Given this list of marker genes BRCA2, RIPK1, OCRL, CCDC40, ALPL, AP3D1, ALDH18A1, RAG1, SPI1, SELENON, IRF3, DYNC2I2, SCN9A (NCBI Gene Id 93955), UBAP2L, IL17RA, SH3KBP1, TSC2, CD3E, TTC7A, RELA, UBE2A, FMO3, MPEG1, NPHS1, DLX4, H4C3, POLE, PRKCD, DPF2, ADNP, MAGT1, NFIX, STAT6, DLL3, EP300, MYO5A, CCBE1, CCDC65, PIGP, MYH3, ALOXE3, FANCF, PRMT7 (NCBI Gene Id 54496), ATP6AP2 (NCBI Gene Id 95880), P4HTM, GLRA2, EPG5, ACBD6, DYRK1A, GRIN1, GAS2L2, GNS, TFE3, RNF168, RFC2, VANGL1, CFAP74 (NCBI Gene Id 93196), MAGEL2, GINS1, CEACAM3, IGHM, AMN, RPL10, NFKB2, PCNT, SLC39A7, NRAS, MC2R, DNAI2, BICC1, CFAP52, RSPH3 (radial spoke head 3), IKZF3, CRELD1 (cysteine rich with EGF like domains 1), NDN, HACD1, MBTPS2, CD40LG, TYMS (NCBI Gene Id 7298), CHAT, BMP4, APRT, DEAF1, TNPO3, ZNF341, CLXN, TERT, FERMT3 (FERM domain containing kindlin 3), C5, SPAG1, ADORA2A, CITED2 (NCBI Gene Id 154106), HELLS, FCGR3A, UNC13D, STXBP2, DAW1, NUP214, SNRPN, RNU7-1 (NCBI Gene Id 100147744), FUCA1, TGM1, TNFSF11 (NCBI Gene Id 8600), CTBP1, SMARCB1, DLG1, ALG13, C3 (complement component 3), TXNRD2, LEP, MMEL1, MAD2L2, FHL1, SPINK5, G6PC3, CPLX1, IKBKB, TARS1, FZD2, CD247, HPGD, FOXJ1, ERCC2 (NCBI Gene Id 7269), TBX1, RAD21, PDGFRA, SIM1, CCDC103, TP53, RYR1, SPTBN4, IGLL1, HGSNAT, KRAS, FOXC2, MAN2B1, ASXL3, CTNNB1, UNG, VARS1, GBA1, TRAF3IP2, CFAP410, COL11A2, HLA-DPA1, PSENEN, IL7R, RAB27A, JAGN1, DNAAF5, SOX11, SLC25A22, ORC6, STAT2, PRKAR1B, MEGF10, MIF, IDS, HBB, CTC1, IGKC, FBXW7, AARS1, DNMT3B, AQP5, IL2RB, SUCLG1, CFD, SMARCA4, SF3B1, ERAP1, WASF1, CD70, POLA1, WFS1, PIK3CG, GALC, DDOST, COL6A2, SKIC2, SLC37A4, CISD2, PLOD1, DNAI1, RECQL, NEUROD2, SP110, C4B, POLD3, SCN2A (NCBI Gene Id 94312), PURA, SCN1B, COL11A1, BCOR, BCHE, IL12RB1, GTF2IRD1, MYPN, PRIM1, BACH2, RSPH4A, WAC, TLR7, CSF3R, GTF2H5, TONSL, NLRC4, CD19, USP48, TNNI3, DEPDC5, TMC8, GNB2, RASGRP1, CCDC22, TMEM70, LAMTOR2, TRAIP, SPIB, RAI1, VAMP1, PLP1, PHKB, HLA-DRB1, SAMD9L, IL12A-AS1, TECPR2, ARPC1B, KANSL1, CR2, FIP1L1, PLCG2, NCF4, AK2, CD28 (CD28 molecule), KCTD1, HBG1, ICOSLG, EYA4, TOP3A, ARPC5, MBL2, JAK1, CLPB, PKD2, COL5A1, MAPK1, THOC6, MCM4, FUT8 (NCBI Gene Id 2530), ANKRD17, GATA2, SCN11A, TSEN34, C8A (complement C8 alpha chain), KRT5 (NCBI Gene Id 3852), TP63, PWAR1, VPS4A (vacuolar protein sorting 4 homolog A), LETM1, SLC35A1, KAT5, PKP1, OCA2, FOXP1, CASP8, SMARCE1, SPTBN1, PHKG2, DCTN4, FARSB, GATA4, TAOK1, UROD, TRPS1, ZAP70, GALNS, NPAP1, SLC19A1, MSX1, TRAF3, MED13L, GORAB, PIGG, TAPBP, CYBA, GAA, NDUFC2, SDR9C7, SBDS, SIK1, IGBP1, RTEL1, IL23R, PSMB10, SERAC1, COG7, ALDH1A2, ERCC4, ARID1A, RFX7, TTC12, CACNA1C, LONP1, XRCC2 (NCBI Gene Id 7516), FADD, PNP, POGZ, P4HA2, CTCF (NCBI Gene Id 10664), GRM7, PAK2, SH2D1A, RFT1, HBG2, FOCAD, SLX4, NELFA, PKD1, NBN, CARD11, POLR2A, IL7, CHRNA3, GLI3, TERC, TRIP11, TPP2, BNC2, GPR35, CLCA4, DNAAF3, KLRC4, POLR3GL, HOXA13, NEK10, GTF2IRD2, RNF113A, FCSK, KMT2B, TSC1, ITK, LAMA2, KATNIP, CXCR2, AGR2, ITGA7, AIRE, MPLKIP, NIPAL4, VPS37D, KLF1, TET2, UROS, DNAAF6, SOX17, TCF4, REL, DOCK2, RPGR, RSPH1, ZBTB16, SMARCC2 (NCBI Gene Id 6601), LTBP4, CD3G, PEX5, SLC39A4, SCNN1A, REEP1, FLNC, IFT56, SNAP25, GFM2, STX1A, EFEMP2, BCR, COL13A1, NHLRC2, PLG, CLDN16, FANCB, IL21, CD4, DIAPH1, MGAT2, AGA, MRTFA, TK2, FBXL4 (NCBI Gene Id 26235), KCNJ6, NLRP3, CCNO, SLC29A3, MED12, WDR26, MGP, SGSH, DGCR6, SLC1A4, DNAJB11, H4C5 (H4 clustered histone 5), RMRP, RALGAPA1, GOT2, WDR19 (WD repeat domain 19), SCNN1B (sodium channel epithelial 1 subunit beta), SATB1, PML, LAMC2, MTM1, C4A, DNAAF1, RBCK1, TRRAP, WASHC5, CRKL, SRY, VPS51, LMNB1, TIMMDC1, IL12A, SRP54, CFB, SLC9A3, A2ML1, SLF2, RAC2, TNFSF12, SMARCA2, ALG5, SMN1, CDH23, GATA6, BCL10, PNKP, POLR1A, GTF2I, SLC7A9, SETD2, NNT, GRIA1, SRCAP, SEMA4D, TRIP4, SAMD9, DPYSL5, IL2RA, C1GALT1C1, CCR2, IRF2BP2, DNAL1, DNAH9, SDCCAG8, RNH1, PYROXD1, SFTPC, CFTR, FKBP6, MGME1, PTEN, DPM2, IFNAR2, DRC1, MNX1 (motor neuron and pancreas homeobox 1), TBX20, LYST, MAP3K20, ARX, KMT2A, ODAD4, PIGU, TRIM37, THRB (thyroid hormone receptor beta), SLC41A1, TBL1XR1, CAVIN1, SNX10, PLEKHM1, ALMS1, TAFAZZIN, AGRN, DNAAF11, RIC1, COL6A1, TRIO, DNAJB13, MKRN3, CARS1, LAT, RAD51, BRWD1, EFL1, IKZF1, PSMD12, ADA2, PSAP, ADAT3, PDHA1, FOXN1, GMNN, FCGR3B, NXN, PGM3, ISG15, NCF1, STAT1, ARL2BP, PPP1R21, MVK, LMBRD1, NEPRO, ALG1, ERF, POLD1, FAT4, MALT1, CD8A, NKX2-1, SLC39A8, TRAF7, BCL2, TFRC (transferrin receptor), GAS8, MST1, USP9X, UBA2, CD55, STX11, MYSM1, FLNA, IDH1, BIRC3, COG6, DZIP1L, RNF31, DNAJC21, LEPR, C7, TBX6, ASAH1, CARD9, OAS1, VPS35L, NFKBIA, CCDC39, UNC119, ORAI1, B3GALT6, DOCK8, IL21R, CTPS1, KAT6A, CLEC7A, LMNB2, TBX21, HLA-DQB1, KAT6B, BUD23, SMARCD2, KCNN4, NUMA1, CD3D (NCBI Gene Id 915), CCR1, NSUN2, MS4A1, KMT2D, UMPS, SMG9, PSEN1, SETD1A, CCDC47, CARMIL2, ARSL, GLUL, KRT1, DNASE2, SLC3A1, PHIP, FCHO1, RNU4-2, MYH6, PRPS1, CDC42BPB, L2HGDH, ELP1, CD40 (CD40 molecule), BRCA1, IRF7, DPP9, BTK, IL6R, RFXANK, BCL11B, PPM1D, ITCH, SNORD115-1, HPS6, MTHFD1, RSPH9, AP3B1, WAS, GEMIN4, HEPHL1, ZNHIT3, ODAD2, PIK3R1, SMARCD1, DDR2, FLT1, CLDN19, PIK3CD, CRIPT, TMEM94, IKBKG, LRBA, RAD51C, CFAP300, VPS45, CDCA7, EBF3, ASPRV1, GNPTAB, CYP4F22, COL2A1, STING1, LRIG2, FMR1 (fragile X messenger ribonucleoprotein 1, NCBI Gene Id 5421), MAP3K14, HERC2, DNAAF4, TMCO1, SHANK3, NOTCH2, SIAH1, NTRK1, LBR, IVNS1ABP, HLA-DPB1, BAP1, GNAO1, ZBTB7A, EDARADD (EDAR associated via death domain), ANAPC1, FANCA, BCL6, UBB, IL12B, KIF15, PHKA2, CYBC1, LIFR, ARID2, TAP2, TMEM270, ICOS (NCBI Gene Id 29851), DDX6 (DEAD-box helicase 6), ARHGEF38, HYOU1, FGFR3, LIMK1, CIITA (NCBI Gene Id 4261), NDE1, TPM2, TF, ZEB2 (NCBI Gene Id 9839), SLC26A2, SLC11A1, NAGLU, IL6ST, MYH11, GJB2, SLC25A1, TNFRSF11A, PRKDC, DGCR8, IL17RC, IRF5, SOCS1, HYDIN (HYDIN axonemal central pair apparatus protein), IFNG, OTULIN, COLQ, FCN3, IRF8, PCGF2, GUSB, RNF125, UHRF1, ATP7A, LIG4, IFIH1, HYAL1, ADA, FANCI, ROR2, LRRC8A, SERPINA1, NCF2, ADAMTS3, TICAM1, RFWD3 (ring finger and WD repeat domain 3), AKT1, IFNAR1, NSD2, STIM1, SLC35A2, CHAMP1, SLC6A19, DNAJC30, ELF4, GCLC, DCLRE1C, RAC1, C6, PSMB4, SASH3, TRAC, STAR, MINPP1, DSG1, RTL1, SULT2B1, KCNA1, STK4, LIG1, PRKAR1A, IL17F, RNF2 (ring finger protein 2), DDB1, CLIP2 (CAP-Gly domain containing linker protein 2), NHEJ1, PLEC, DMXL2, SLC6A14, WRAP53, KMT5B, IRF9, LIPN, XIAP, ALG12, MDFIC, IDUA, C8B, DNASE1L3, ATN1, TASP1, ATRX, EGFR, CFH, LAMA3, PARN, ZBTB24, CORO1A, RELB, ACVRL1, CEBPE, EN1, ALG9, ARL3, SETBP1, PEPD, FANCD2, RPS14, STAT3, DEF6, MANBA, SLC52A3, TOM1, DLK1, MCM10, ITGA3, IFT122, PIGQ, SNORA31, UGP2, TYK2, HLA-B, FBXO11, MCIDAS (NCBI Gene Id 649510), RPL11, NR3C1, EXTL3, MBD5, COL4A5, SLC35C1, HPSE2, METTL27, BTD, AASS, CD81, ZMYND10, STAT4, SOX4, SON, TLR8, WDR35, ELN, ZNFX1, NBEA, IRF1, ARHGEF1, POU2AF1, CORIN, FANCM, INSR, NABP1, IRAK4, ODAD3 (NCBI Gene Id 115948), TNFRSF1A, MLXIPL, SLC5A2, ERCC3, PI4KA, DBR1, TNFSF15, BLNK, ELANE, SNORD116-1, ALB, MYO9A, COL4A6, ASXL1, SHROOM4, COG4, ACTA1, IL10RA, MIR140, EIF2AK3, MESP2, TBCE, SLC18A3, DYM, SYT2, TCTN3, CDH1, HMOX1, SREBF1, FLVCR1, CARD10, STK36, NGLY1, TNRC6B, CFAP221 (NCBI Gene Id 200373), DNAAF2, OFD1, ANTXR2, LIG3, WIPF1, MYD88, FAS, TNFRSF9, NAA10, SLC26A9, PCYT1A, ATP6AP1, SPEF2, ATP6V0A2, DNAH1, RFXAP, MNS1, CFI, LTBP1, ACP5, PALB2, UBE2T, PTPN6, FANCE, GSTM3, CTNNBL1, RAB3GAP2, MEFV (NCBI Gene Id 4210), DKC1 (NCBI Gene Id 1736), PI4K2A, STAT5B, KIAA0586, IL2RG, DNAH11, NOP10, CASK, NFKB1, DHCR7, TBK1, GTF2E2, IFNGR2, KDM6A, RAP1B, HCK, ATM, BRAF, ZNF668, PLVAP, NME8, NKX2-5, SKIC3, MYL2, CACNA1B, NFASC, RNU4ATAC, GFI1, INPPL1, SYK, AICDA, FANCL, ESS2, FLI1, NECTIN1, KPTN, TP73, DIP2B, MASP2, GRIA3, MED25, TSEN54, ABCA12, TNFRSF13C, HAX1, CD27, BAZ1B, ZNF699 (zinc finger protein 699), EIF4H, CTSC, TBCD, POMP, TPM3, USP8, SLC5A7, IRF4, C1QA, ODC1, RARA, TBC1D24, MRAP, SLC32A1, CHRM3, TSEN2, AGXT, CD79A, MEG3, SMPD1, SEC61A1, MECP2, ARSB, FBXO28 (NCBI Gene Id 23219), NME5, GIMAP5, MAP3K7, NPM1, POLR3A, LCK, CEACAM6, KNSTRN, ISL1, PRF1, KMT2C, ECM1, BCL11A, BLM, IFT140, TCEAL1, YY1, USB1, TLR3, CTLA4, CSPP1, TSEN15, MYL9, GJB6, TNNT2 (troponin T2, cardiac type), ACTC1, TINF2, TCF3, CFAP298, TCIRG1, MCTS1, ALOX12B, TLR4, PDCD1, PRTN3, FLII, C1QC, COBLL1, IL10RB, ENG (NCBI Gene Id 2022), SEPSECS, TNXB, TLL1, FOXP3, TRIM8, BPTF, CD79B, CREBBP, IGHG2, GATA1, ALG3, PSMB8, PET117, HSPA9, EPHB4, B2M, EOMES, LRRC56, FANCC, IARS1, DNAH5, DGCR2, COG1, C1QB, GANAB, LAMB2, IL10, UFC1, UQCRH, TBC1D23 (NCBI Gene Id 55773), SERPINH1, USP26 (NCBI Gene Id 83844), MSN, ITGB2, TAF4, KIF20A, TBL2, SCN10A, DOHH, UROC1, IER3IP1, SLC2A1, PKHD1, LCP2, RAG2, COL5A2, GRHPR, SPPL2A, FOXP2, CLTRN, FBLN5, GLIS3, MDM4, RORC, KRT14, PWRN1, FANCG, TNFRSF13B, ERCC6, SOX9, ODAD1 (outer dynein arm docking complex subunit 1), SLC7A7, NCKAP1L, UBAC2, UBE3B, WDR1, IQSEC2, TGFB1, EDNRA, SLC4A10 (solute carrier family 4 member 10), HFE, RFX5, IRF6, SRP19, SIN3A, NFE2L2, CXCR4, VPS33A, FCGR2A, NAE1, BRIP1, POLR3F (NCBI Gene Id 115527), CPSF3, STOX1, GLB1, PGM1, CLCN7, STX3, RUNX2, CBLB, ATR, CDC42, UNC93B1, SLC46A1, ADAM17, LAMB3, EXT1, EXOSC9, SCNN1G, EHMT1, IFNGR1, C1R, TAP1 (NCBI Gene Id 92050), DRG1, ARID1B, DDX59, CYBB (NCBI Gene Id 1536), ARHGAP29, CDKL5, NHP2, PTPN22 (protein tyrosine phosphatase non-receptor type 22), SMARCAL1, KDM5C, GRHL3, DOCK11, JAK3, here is a description of the gene set: Human Gene Set: HP_UNUSUAL_INFECTION A type of infection that is regarded as a sign of a pathological susceptibility to infection. There are five general subtypes. (i) Opportunistic infection, meaning infection by a pathogen that is not normally able to cause infection in a healthy host (e.g., pneumonia by Pneumocystis jirovecii or CMV); (ii) Unusual location (focus) of an infection (e.g., an aspergillus brain abscess); (iii) a protracted course or lack of adequate response to treatment (e.g., chronic rhinosinusitis); (iv) Unusual severity or intensity of an infection; and (v) unusual recurrence of infections. Unusual infection species: Homo sapiens